Given this list of marker genes POLR2E, POLR1G, POLR2K, POLR1E, POLR1H, POLR1F, POLR1A, POLR1B, POLR2H, POLR2F, POLR2L, POLR1C, POLR1D, here is a description of the gene set: studied in species Homo sapiens RNA polymerase I, one of three nuclear DNA-directed RNA polymerases found in all eukaryotes, is a multisubunit complex; typically it produces rRNAs. Two large subunits comprise the most conserved portion including the catalytic site and share similarity with other eukaryotic and bacterial multisubunit RNA polymerases. The remainder of the complex is composed of smaller subunits (generally ten or more), some of which are also found in RNA polymerase III and others of which are also found in RNA polymerases II and III. Although the core is competent to mediate ribonucleic acid synthesis, it requires additional factors to select the appropriate template. Human Gene Set: GOCC_RNA_POLYMERASE_I_COMPLEX